The following is a description of a gene set: species: Homo sapiens Human Gene Set: DESCARTES_FETAL_EYE_BIPOLAR_CELLS from publication Cao J, O'Day DR, Pliner HA, Kingsley PD, Deng M, Daza RM, Zager MA, Aldinger KA, Blecher-Gonen R, Zhang F, Spielmann M, Palis J, Doherty D, Steemers FJ, Glass IA, Trapnell C, Shendure J (PMID 33184181) Marker genes curated from the annotated cluster as represented in the Descartes Human Gene Expression During Development database. The gene expression program underlying the specification of human cell types is of fundamental interest. The study authors generated human cell atlases of gene expression and chromatin accessibility in fetal tissues. For gene expression, the study authors applied three-level combinatorial indexing to >110 samples representing 15 organs, ultimately profiling ~4 million single cells. The study authors leveraged the literature and other atlases to identify and annotate hundreds of cell types and subtypes, both within and across tissues. Our analyses focused on organ-specific specializations of broadly distributed cell types (such as blood, endothelial, and epithelial), sites of fetal erythropoiesis (which notably included the adrenal gland), and integration with mouse developmental atlases (such as conserved specification of blood cells). These data represent a rich resource for the exploration of in vivo human gene expression in diverse tissues and cell types., and this is the list of marker genes: GNL2P1, GSG1, GLRA1, TMEM215, NETO1, VSX1, GABRR1 (gamma-aminobutyric acid type A receptor subunit rho1), TAFA4, KCNMA1-AS1, HHIP, LINC03098, ZNF804B, TACR3, LINC02821, CA10, IGSF21, ENSG00000228566, LACTBL1, GRIK1, ENSG00000227863, KIRREL2, NETO1-DT, GABRR3, ZPBP, SSTR2, GABRA5, SERTM1